Given this list of marker genes MIR29B1, CITED1, TGFBR1, LTBP3, FERMT2, CCNE1, VEGFC, TGFB1, MIR16-1, MIR181A2, here is a description of the gene set: Human Gene Set: GOBP_REGULATION_OF_MESENCHYMAL_STEM_CELL_PROLIFERATION Any process that modulates the frequency, rate or extent of mesenchymal stem cell proliferation. species: Homo sapiens